Given this list of marker genes Ttf2, Htr1f, Dnaaf6, Rbfox1, Or51l4, Utp6, Bbs2, Rnf214, Fem1c, Echdc1, Adgrl4, Synj1, Nexmif, Aak1, Pcdhb11, Med14, Ppp4r4, Hic1, Taf5, Grin1, Gucy1b1, Stxbp5, Cypt14-ps, Cyth3, Prkacb, Abcb7, Zswim6, Atp6v1c1, Nrg3, Vmn1r32, Tfg, Usp43, Kcnmb2, Smarca2, Fam120a, here is a description of the gene set: Mouse Gene Set: MIR_144_5P studied in species Mus musculus Genes predicted to be targets of miRBase v22 microRNA mmu_miR_144_5p in miRDB v6.0 with MirTarget v4 prediction scores > 80 (high confidence targets). from publication Chen Y, Wang X (PMID 31504780)